The following is a description of a gene set: Mouse Gene Set: GOMF_ENDOPEPTIDASE_REGULATOR_ACTIVITY Binds to and modulates the activity of a peptidase, any enzyme that hydrolyzes nonterminal peptide bonds in polypeptides. studied in species Mus musculus, and this is the list of marker genes: Serpinb6e, Aplp2, Mug1, Serpine3, Mug2, Serpinb5, Sorl1, Birc7, Serpinb1a, Serpind1, Agt, Nlrp1a, Psme2, Serpinb9f (serine (or cysteine) peptidase inhibitor, clade B, member 9f), Serpinb2, Gapdhrt2, Serpina3g, Rarres1, Kng1, Serpinf1, Smr3a, Wfdc17, Cd109, Gm7298 (predicted gene 7298), Psmf1, Itih3, Spink11, Bst2, Cstdc5, Hspd1, Ctla2b, Col6a3, Papln, Timp1, Tfpi, Wfdc13, Cstdc6, Aph1b, Wfdc6a, Thbs1, Prnp, Spink13, Wfdc12, Xiap, Spink6, Uchl5, Spink1 (NCBI Gene Id 20730), Wfdc2, Smr2, Itih5 (inter-alpha-trypsin inhibitor, heavy chain 5), Usp14, Crb2, Spint3, Cst5, Aph1c, Anxa2, Pttg1, Aph1a, Timp2, Ncstn, Serpini2, Serpina1e, Wfdc1, Serpinc1, Csn2, Serpina16, Cst12, Wfikkn1, Serpina3j, Stfa1, Serpinb6d, Bad, Wfdc8, Spock3, Rock2, Serpina9, Cstdc3 (NCBI Gene Id 209324), Serpinb6c, Elp2, Ltf, Kng2, Serpinb9b, Wfdc15b (WAP four-disulfide core domain 15B), Gbp2, Gbp5, Furin, C3, Gapdh, Serpinb8, Cst3, Timp4, Serpinb11, Cst9, Col7a1, Serpinb3b, Serpinb3c, Serpina11, Timp3, Spink4, Serpina5, Serpinb9h, Wfikkn2, Serping1, C4b, Wfdc9, Fetub, Cast, Serpina7, Mansc4, Lxn, Wfdc5, Serpina3c, Stfa3, Serpina3f, Spink7, Serpina1b, Wfdc21, Serpinb7, Cst8, Serpina3m, Cstdc1, Serpinh1, App, Wfdc3, Wap, Abca2, Cstl1, Bin1, Pcsk1n, Serpinb9g, Psenen, Birc6, Lgmn, Pebp1, Serpina3i, Spink10, Itih4, Nlrp2, Serpine2, Serpinb1b (NCBI Gene Id 76168), Stfa2, Spink12, Serpina12, Col28a1, Csta1, Ambp, Serpina1c, Ngf, Serpina3n, Serpina3k, Vsir, Serpina10, Spink2, Psme3, Wfdc10, Spint1, Spink5, Spink8, Reck, Serpina3b, Serpinb13, Itih1, Serpinb6a, Nlrc4, Tfpi2, Spint4, Gbp2b (NCBI Gene Id 677276), Crim1, Timm50, Stfa2l1, Serpina1f, Aim2, Serpinb9c, Serpinb3a, Serpinb10, Serpinf2, Pycard, Serpinb9d, Psme1, Adrm1, Hc, Serpina6, Csta2, Itih2, Wfdc16, Birc5, Serpinb9, Serpinb12, Adrm1b, Nlrp3, Cstdc4, Serpina1d, Nlrp1b, Spock1, Spint2, Psmd14, Slpi, Smr2l, Serpina3a (serine (or cysteine) peptidase inhibitor, clade A, member 3A), Hrg, Serpinb3d, Sfrp2, Pbp2, Serpine1, Cstb, Serpini1, Cst11, Malt1 (NCBI Gene Id 240354), Pzp, Naip1, Serpinb6b, Wfdc11, A2m, Cst7, Snca, Eppin, Csta3, Wfdc6b, Wfdc18, Serpina1a, Arrb1 (arrestin, beta 1), Gapdh-ps15, Wfdc15a (WAP four-disulfide core domain 15A), Ngp, Ahsg, Gapdhrt, Serpinb9e, Cst13, A2ml1, Serpinb1c